Given this list of marker genes Uba52rt, Rps27a, Ube2d1, Rnf128, Otud7b, Tnip1, Vcp, Otud3, Otud7a, Traf6, Esr1, Vcpip1, Ripk1, Nod1, Pten, Ubb, Tnfaip3, Otub1 (OTU domain, ubiquitin aldehyde binding 1), Apc, Zranb1, Tnip2, Tnip3, Ikbkg, Yod1, Nod2, Ubc (ubiquitin C), Otub2, Traf3, Uba52, Trp53, Rhoa, Ripk2, Cdk1, here is a description of the gene set: species: Mus musculus Mouse Gene Set: REACTOME_OVARIAN_TUMOR_DOMAIN_PROTEASES Ovarian tumor domain proteases